Given this list of marker genes Cyp2c39, Sult2a6, Gsta5, Fmo4, Cyp3a11, Cyp26b1, Cyp2u1, N6amt1, Cyp2j5, Grin1, Cyp1a1, Nceh1, Cyp2ab1, Acsl1, Cyp2j9, Cbr1, Cyp3a16, Cyp2j13, Aldh2, Slco1b2, Gsto1, Gstp2, Ugt2b1, Cyp2d12, Nos1 (NCBI Gene Id 76730), Cyp2c65, Cyp2d11, Sult1a1, Lpo, Cyp46a1, Gsta2, Cyp1a2, Cyp2t4, Cyp2c50, Cyp2d26, Tpmt, Cyp2c38, Aox4, Sult2a1, Gsta13, Cyp2e1 (NCBI Gene Id 13106), Cyp3a44, Abcc2, Akr1c13, Ugt1a6a, Cbr1b, Cyp2c70, Cyp3a41a, Gstm5, Cyp2f2, Cyp2c55, Cyp2j7, Cyp2b13, Cyp1b1, Acaa1a, Cyp2c29, Sult2a3, Cyp2r1, Aox2, Gstt1, Cyp2d34, Acaa1b, Sult2a4, Slco1a6, Akr1c12, Cyp2c23, Cyp2a12, Cryz, Rorc, Gstp3, Guk1, Cyp2a5, Star, Vkorc1 (NCBI Gene Id 27973), Gstm4, Aox3, Gsta1, Cyp2j8, Cyp2d9, Aox1, Sult2a7, Cyp2c66, Cyp2d10, Fmo2, Gsta4, Cyp2c37, Ahrr, Cyp3a41b, Abcb11, Ugt1a1, Cyp2a4, Ahr, Gsta3, As3mt, Gstp-ps, Slco1a1, Cyp2j6, Cyp2c69, Cyp2b23, Pon3, Aip, Cyp2b9 (NCBI Gene Id 13094), Sult1c1, Nr1i2, Cyp2d22, Ugt1a6b, Cyp2c40, Fmo1, Gstm1, Cyp2g1, Sult2a8, Cyp2c67, Cyp2s1, Cyp2c68, Cyp2a22, Sult1b1, Hnf4a, Nudt15, Cyp2b19, Cyp2j11, Fmo5, Cyp2c54, Gstm7, Cyp26a1, Cyp2j12, Gstm2, Gsto2, Fmo3, Gstm3, Gstp1, Cad, Cyp2w1, Sult2a5, Sult2a2, Cyp2b10, Rora, Gstm6, here is a description of the gene set: studied in species Mus musculus Mouse Gene Set: GOBP_XENOBIOTIC_METABOLIC_PROCESS The chemical reactions and pathways involving a xenobiotic compound, a compound foreign to the organism exposed to it. It may be synthesized by another organism (like ampicilin) or it can be a synthetic chemical.